Given this list of marker genes NFAM1, KLK4, ARHGEF9, IMPDH1, EYA3, BAK1, MYOM1, GABBR2, AURKA, NEMP2, KICS2, BACE2, ISLR (NCBI Gene Id 3671), PHF8 (PHD finger protein 8), AHCY, NECTIN1, ANO6, ZMYM3, SLC1A3, HOXB9, AIF1L, PIANP, METTL21A, SRP54, TET3, MEF2D, SH3PXD2B, NALF2, ESRRG, C20orf96, SKI, LRP2BP, ATP6V0D1, CS, SHISA7, NFIX, HOXC10, PTK2, UBE2D3, MEIS3, ABCG4, NCOR2, JCAD, KCTD13, PRRT2, HTT, SGMS1, KLHL9, WDTC1, SAMD4A (NCBI Gene Id 26078, sterile alpha motif domain containing 4A), IL2RB, ARL6IP5 (ADP ribosylation factor like GTPase 6 interacting protein 5), ADAMTS4, RAB3IL1, HPCA, MAP3K9, PLXNA1, HSD17B13, KDM5C, DNA2, ADO, ADGRE5, SPRN, CD300LD-AS1, LSM8, ELFN2, PLAGL2, FZD1, NAV2, BZW1, KLHDC10, NISCH, RND1, WNT1, PSD3, REG1B, DMBX1, IL2RG, LRRTM1, WASF2, CREB3L2, UBE2O, LASP1, SOHLH2, HNRNPA2B1, DLK1, HNF4A, CCDC169-SOHLH2, NDUFA4L2, SSH1, RBM43, OXCT2, KSR2, PDLIM5, TBC1D24, SEC31A, KLHL13, LSAMP, UBE2W, ZFHX3, SNU13, NFAT5, SLC2A3, GATAD2B, NGF (nerve growth factor), DLX3, CASC3, RASSF3, OPA3, POU2AF1, AR, LENG8, CD44, NSG2, YTHDC2, BLTP3A, SEMA4G, STK16, ULK1, IGFBP4, CETP, NDUFA10, SOX12, RNF103, ADD2, SDK1, PAX1 (paired box 1), ZNF444, NOVA2, CDHR1, CRTC2, PCYT1A, CBX6, HECTD4, TP53INP1, DTX1, FBN2, CERS2, TRIM3, ACKR2, WNT9B, ITGA8, SOX13, FGF23, HERC3, here is a description of the gene set: from publication Chen Y, Wang X (PMID 31504780) Genes predicted to be targets of miRBase v22 microRNA hsa-miR-4739 in miRDB v6.0 with MirTarget v4 prediction scores > 80 (high confidence targets). Human Gene Set: MIR4739 species: Homo sapiens